The following is a description of a gene set: Mouse Gene Set: GOCC_RDNA_HETEROCHROMATIN A region of heterochromatin located at the rDNA repeats in a chromosome. species: Mus musculus, and this is the list of marker genes: Baz2a, Nop53, Sirt1, Suv39h1 (NCBI Gene Id 20937), Rrp8